The following is a description of a gene set: Genes predicted to be targets of miRBase v22 microRNA mmu_miR_5615_3p in miRDB v6.0 with MirTarget v4 prediction scores > 80 (high confidence targets). from publication Chen Y, Wang X (PMID 31504780) Mouse Gene Set: MIR_5615_3P studied in species Mus musculus, and this is the list of marker genes: Usp31, Mbnl1, Grm1, Lgi2, Lnpk, Glod4, Malrd1, Ppp3r2, Lyz1, Ecm2, BC031181, Tead1, Susd2, Rpusd2, Sbf2, Tmem238, Zic4, Klk9, Gpr183, Flywch1, Oas1g, Prkg1, Dclre1c (DNA cross-link repair 1C), Sco1, Pbld2, Phyhip, Dlx2, Atp6v0d1, Angptl3, Sh3gl2, Pmp2, Ttc3, Ccdc116, Rock2, Nr1h4, Sox6, Fsbp, Agpat3, Rnf103, Ift56, Epha4, A430033K04Rik, Trmt11, Fnip2, Luc7l3, Slc35e1, Trem5, Kdelr2, Rab2a, Gna14, Fbxo28, Usf3, Oog2, Prtn3, D430041D05Rik, Anxa10, Eppk1, Ltbp4, Atp6ap2, Mex3b, Tcf25, Xbp1, Myoz3 (NCBI Gene Id 74611), Tex2, Slco1c1, Bdh1, Sgip1, Eya1, Fgd6, Gfra2, Sec23a, Aff4, Atp2b1, Fmn1, Urgcp, Atoh1, Bdnf, Tacr1, Slc10a5, Nrxn1, Zdhhc9, Xkrx, Syk, Mfsd4b5, Gabarapl2, Scara5, Gdpd1, Clpp, Rnf214, Srp54b, Kcnb2, Bag4, Gipc3, D630023F18Rik, Arfgef1, Samd8, Ergic2, Fyn, Dynap, Dkk4, Dzank1, Dolpp1, Slc35e2, Armc8, Scai, Dpysl2, Kcnk10, Cdh12, Zfp128, Galnt10, Cyp2b19, Clns1a